The following is a description of a gene set: Mouse Gene Set: GOBP_RESPONSE_TO_CELL_CYCLE_CHECKPOINT_SIGNALING species: Mus musculus A process that occurs in response to signals generated as a result of cell cycle checkpoint signaling., and this is the list of marker genes: Rbm14, Eme1, Smc1a (structural maintenance of chromosomes 1A), Fbh1, Mus81, Zmpste24, Slx4, Tigar